Given this list of marker genes OIT3, GANC, ZC3H11A, VSTM2A, MEIOC, ASPH, TUSC1 (NCBI Gene Id 389708), PI15, MYO18A, F2RL2, BAK1, TEAD1, CDH19, AMMECR1L, MPZL1, PICALM, GBP4, SGPP1, CFAP300, PCDHB10, GUCY2C, NWD2, EPB41L4B (erythrocyte membrane protein band 4.1 like 4B), VCF1, ZC3H11C, EPC1, GAB1 (GRB2 associated binding protein 1), TET3, ACTG1, MFSD8, PRSS12, AQP4, DMP1, LANCL2, SHROOM3, GIPC2, PPP1R13B, DCAF5, IQGAP3, RPP30, here is a description of the gene set: Human Gene Set: MIR503_3P species: Homo sapiens from publication Chen Y, Wang X (PMID 31504780) Genes predicted to be targets of miRBase v22 microRNA hsa-miR-503-3p in miRDB v6.0 with MirTarget v4 prediction scores > 80 (high confidence targets).